Given this list of marker genes PPP2R5D, PPP2R1B, PFKFB2, PRKACA, PFKFB4, PRKACG, PFKFB1, PPP2CB, PFKFB3, PRKACB, PPP2CA, PPP2R1A, here is a description of the gene set: Reactome Pathway: Regulation of glycolysis by fructose 2,6-bisphosphate metabolism part of: Glycolysis The committed step of glycolysis is the phosphorylation of D-fructose 6-phosphate (Fru(6)P) to form D-fructose 1,6-bisphosphate, catalyzed by phosphofructokinase 1 (PFK) tetramer. PFK can be allosterically activated by D-fructose 2,6-bisphosphate whose levels are increased in response to insulin signaling and decreased in response to glucagon signaling, through the reactions annotated here. species: Homo sapiens